The following is a description of a gene set: Dendritic cells (DCs) process and present self and foreign antigens to induce tolerance or immunity. In vitro models suggest that induction of immunity is controlled by regulating the presentation of antigen, but little is known about how DCs control antigen presentation in vivo. To examine antigen processing and presentation in vivo we specifically targeted antigens to the two major subsets of DCs using chimeric monoclonal antibodies. Unlike CD8+ DCs that express the cell surface protein CD205, CD8- DCs, which are positive for the 33D1 antigen, are specialized for presentation on MHC class II. This difference in antigen processing is intrinsic to the DC subsets and associated with increased expression of proteins associated with MHC processing. studied in species Homo sapiens from publication Dudziak D, Kamphorst AO, Heidkamp GF, Buchholz VR, Trumpfheller C, Yamazaki S, Cheong C, Liu K, Lee HW, Park CG, Steinman RM, Nussenzweig MC (PMID 17204652) Genes up-regulated in cells from Flt3L Melanom injected mice: 33D1+ versus B lymphocytes. Human Gene Set: GSE6259_FLT3L_INDUCED_33D1_POS_DC_VS_BCELL_UP, and this is the list of marker genes: ADAP1, FARSB (phenylalanyl-tRNA synthetase subunit beta), RAE1, STARD7, AKR7A2, CLUH, DCST2, SERP1, UBE3D, OLA1, GTF2H2, SNAPC1, USP14, PCNX4, INSIG1, HSPE1, DAB1, CHCHD1, SMYD2, WDR18, POLR2K, GLRX5, SLC39A10, RSAD1, METTL5, NR2E3, PPARA, CASQ2, BEND3, ADPGK, MRM3, ITIH5, WDR75, POLR1F, RGS10, MPC1, MRPS10, NMD3, NDUFA5, MGAT2, BMP8A, RPL35, GEMIN6 (NCBI Gene Id 79833), UCHL3, TRIML1, GPD1L, YBX3, DDX10, NINJ1, SAMM50, CETN3, TMEM150A, FGD6, RASGRP2, AKNAD1, TRMT10C (tRNA methyltransferase 10C, mitochondrial RNase P subunit), SEC24D, MRPL21, RPAP3, ENO3, MRI1, FGD2, GNPTAB, NDUFB2, SELENOI, UQCC6, CCT3, PQBP1, PIGU, EIF3I, AFG2B, CAD, NUFIP1, MTG1, CD2, EIF5, ARMC1, PRDX3, NTMT1, EXOSC5, ZFP36, GIMAP4, NSUN5, MRPL46, CHCHD4, MIPEP, SRSF7, NRBF2, C8orf76, PARP1, PRMT3, POLR1G, NME6, BEX1, DDX39A, ERH, MRPS22, SDF2L1, MRPL12 (mitochondrial ribosomal protein L12), MRPS30, RPUSD2, POLD2, PES1, ZNF235, NUBP2, UXT, DDX31, EMC6, POLR3A, TRMT61A, PTPMT1, SPCS3, UQCR11, USP16, ZNRD2, TOP1MT (NCBI Gene Id 116447), METAP2, SLC44A2, PSMG3, HACD1, DCUN1D5, NOC4L, CLNS1A, MRPS34, UQCRFS1, ST13, NAGPA, CARNMT1, GLS, CD53, GTF2E1, SLC30A4, TNK2, PSMB5, GPR65, PHB1, FKBP11, HECTD1, ORC2, GCAT, MYCBP, GIMAP7, NOP16, YIPF6, TIMM21, SCO1, NSFL1C, FBXO31, CORIN, B3GALNT2, SLC25A32, CRLS1, FXN, ARL1, FITM2, EIF2B5, MSANTD3, GIMAP6, GET1, VAT1, UTP4, CYB5B, METTL13, PIM3, RRP9, RPP14, NAF1, TPP2, CDPF1, IFT70A, TMED5, RECK, RCE1, FAM185A, ST6GALNAC4, TEX29, OGFOD2, C1QTNF2, COL8A1, OGFOD3, TMEM223, NHP2, NDUFAF6, LSM12, SNRPA1, RAP1GAP2, DDX21, TXNRD3, RXYLT1, ZNF428, C3orf80, TMEM243, IMP4, PWP2, NOP9, TIMM23 (translocase of inner mitochondrial membrane 23), ARMC6, AARSD1, NOL11